The following is a description of a gene set: from publication Chen Y, Wang X (PMID 31504780) Human Gene Set: MIR3151_5P Genes predicted to be targets of miRBase v22 microRNA hsa-miR-3151-5p in miRDB v6.0 with MirTarget v4 prediction scores > 80 (high confidence targets). species: Homo sapiens, and this is the list of marker genes: SEMA6A, CADM1, SPATA31D3 (SPATA31 subfamily D member 3), NAA60, KLF2, SPATA31D4, INPP5A, GNG13, SNAI1, MEIS1, GOLPH3L, ABCE1, STIM1, HOXC8, VAV2 (vav guanine nucleotide exchange factor 2), ZCCHC13, UCN2, KIF21B, CAMTA2, CDH11, SLC30A2, TPPP, DCDC2C, TMEM132E, CRMP1, C1orf167, DOCK3 (dedicator of cytokinesis 3), MEP1A, NECTIN1, GTPBP2, SNW1, C9orf50, ARHGAP33, SMG5, ERF, HNRNPA0, DRP2, ADD1, SNX32, FCMR, CAPN1, ZNF234, CAMK1G, ZNF213 (NCBI Gene Id 9233), CPSF7 (NCBI Gene Id 79869), RPRD2, SPRN, FBXO41, FAM120A, ADH1B, NAA35, CCDC97